The following is a description of a gene set: Annular constrictions around the digits, limbs, or trunk, occurring congenitally (sometimes causing intrauterine autoamputation) and also associated with a wide variety of disorders. Constrictive amniotic bands are the result of primary amniotic rupture, which can lead to entanglement of fetal tissue (especially limbs) in fibrous amniotic strands. Amniotic constriction ring species: Homo sapiens Human Gene Set: HP_AMNIOTIC_CONSTRICTION_RING, and this is the list of marker genes: KRT1, FERMT1, KANK2, TP63, SMARCAD1, GJB2, LORICRIN, GJA1, TRPV3, POMP, GLE1